The following is a description of a gene set: Human Gene Set: MIR95_5P Genes predicted to be targets of miRBase v22 microRNA hsa-miR-95-5p in miRDB v6.0 with MirTarget v4 prediction scores > 80 (high confidence targets). species: Homo sapiens from publication Chen Y, Wang X (PMID 31504780), and this is the list of marker genes: LPP, ERCC4, FOXD4L5, HARS1 (histidyl-tRNA synthetase 1), MTHFD2, TXNRD1 (thioredoxin reductase 1), ERAP1, NKIRAS2, CD2AP, FRG2, HEXB, MEP1A, RIC1, AMN1, ACP7, MTR, SDE2, DOK6, PLEKHG3, PDE4D, FEZF1, SLC7A10, ATG14, IL10RA, STXBP4, CIPC, TMX3, RORA, KIF20A, GPM6A, COL19A1, SMAD2, NOL7, HGF, PRTG, TRMT9B, KCNJ2, DCAF5, PSMC2, MAP3K10, SGTB, C5orf15, BRPF3, NADK2, TOR1A, NOTCH1, MYO10, SLC12A6, CTBP2, TRA2A, FBXO33, ELMOD1 (NCBI Gene Id 648653), CD164, EIF4A1, OGA, INO80D, CPEB3, TRIM14, AK9, ANOS1, CACHD1, COQ10B (NCBI Gene Id 80219), COLGALT1, FGFR3 (NCBI Gene Id 55546), CSRNP2, POGZ, PTGS2, PPP1R12A, RFX3, CPEB2, DMRTA1, FST, SGK1, NRG1, GK, CD69, PRKAA2, ZDBF2, LSM8, NET1, TET3, ASB8, C2CD4B, TMEM33, YPEL3, PTBP3, MAGI2 (NCBI Gene Id 9863), SLC2A4RG, TGFB2, PTPN11, YOD1, TMEM252, MINDY2, FAM168A, LCORL, CAMK1, GSK3B, CLIP4, ALCAM, TFDP1, GTF2A1, PHOX2A, COP1 (COP1 E3 ubiquitin ligase), TAFA1 (NCBI Gene Id 494552), YIPF6, RORB, IDI1, RAP2A, TMEM200B, SNAPC1, KCNA3, TBX3, WWP1, DMPK, FGF18, INPP5A (NCBI Gene Id 3632), LPGAT1, DTWD2, PDIK1L, GABRA1, KITLG, LRRC39, SLAIN1, ZNF512B, MIER3, DLEU7, RNF180, SNX27, SPEG (striated muscle enriched protein kinase), DNAJC15, CLDN1, ZBTB20, ATL2, GPR63, ABTB2, CIR1, OCRL, SPDYE5, DHX15, B3GLCT, FAT4, MXD3, PTGER3, KLHL8, JKAMP, CDK17, PMS1, GTPBP2, ATXN1, PCGF3, NR3C1, PRKCE, PIK3CA, ZBTB21, MAP3K13, MBD5, PPP1R2, SEMA7A, POMGNT2, EBF3, KCTD9, NBEA, TMEM182, GPR65, TBCA, PPP6C, MAFF, SLTM, CAMSAP1, ERBIN, COX7A2, ANKRD22, TIAM2, PTPN4 (NCBI Gene Id 5775), CCDC50, RASSF8, CD28, CAV2, FAM222B, AADACL4, MYSM1, RAB11A, NXPH2, IFT56, FSIP1, GOLGA2, BCL6B, PLCL2, FBXO45, SCAMP1, GDAP2, MMUT (NCBI Gene Id 4594), PYGO1, GPATCH2L, MACIR, C5orf24, SESTD1, MYO1E, SEC14L1, PPP4R3A, SLC7A14, UBA6 (NCBI Gene Id 55236), JRKL, GRIA2, TMEM236, CCT5, ADCYAP1, IFFO2, PHF21B, MMP16, SLC35D1, PLEKHG1, PRPF38B, MAFK, SPDYE3, DYRK2, RRP15, RAD51C, STT3B, NUBPL, RIMS4, ZSWIM4, CASKIN1, LRATD2, ASTN2, AKIRIN2, MBTPS2, RSRC2, MSX2, ATP11B, ZBTB22, TMLHE, EVI5, PGBD2, STX12, TXNDC11, EPC1, HTR2A, CBFB, DRD1, IL27, N4BP2, POMGNT1, FAM216B, SMIM13, KCMF1, SKIL, ANKRD6 (NCBI Gene Id 22881), ARPC5L, PARVA, TMEM97, INTS6L, CBLB, STARD3NL, G3BP1, TCF12, ZEB1, SEMA4G, CRPPA, FNDC3B, TP53BP2, SDR9C7, FSD1L, CEP20, BAHCC1, AMOT, PDP1, C6orf120, ST6GALNAC5, ZNF550, ZNF770 (NCBI Gene Id 54989), DPYS, SPTY2D1, C1orf74, RANBP6 (NCBI Gene Id 26953), UBE2W, PDZRN4, ACTL6A, SREK1IP1, SPATS2L, TMED5, STAMBPL1, CEP43, MPZL3, IKZF2, CFAP418, GRK3, TMEM135, COL9A1, OSBPL6, RBM17, RS1, TMX4, SLC25A38, GNAQ, SETBP1, SELENOT, SRRM4, ARL8A, MOCS2, MBTPS1, SLC13A2 (NCBI Gene Id 9058), APOOL, CXCR4, FERMT3, ZC3H12C, GFOD1, ZNF345, LRRC59, SLF1, USP7, WDR44, PSTPIP2, ZNF461, PIKFYVE, SMAD9, HYCC1 (NCBI Gene Id 84668), SCN8A, DIS3, DIXDC1, TRIM5, AMFR, SPRY1, PIGH, FBXL5, ANKRD12, KDM5C, LARP1, PARP8, SMG8, PRMT2, PPFIA3, WIPF3, CASP7, SEMA3F, SLC24A4, ACTR8, PPP1R1C, MRPL19, FNIP1, CCNJ, CLASP2, STAB1, ZFP14, GEMIN2, CTSC, GDNF, PLK3, HOXC5, RETSAT, ATP6V0B, ZC3H6 (zinc finger CCCH-type containing 6), POLR2K, ST3GAL1, ACTR1A (NCBI Gene Id 10121), CCNE1, ZNF772, SAV1 (NCBI Gene Id 60485), TAGAP, RSBN1, LMNTD2, SLC25A22, FOXN4, GORAB, MBLAC2, STC1, OAZ1 (NCBI Gene Id 4946), IMPG2, ZNF106, CNTN1, C14orf39, CRAMP1, AFF4, MORF4L2, EMC1, TMTC2, MYCBP2, TET1, MYT1L, ICAM1, LRP2BP, ZNF215, FRK, TEAD1, ARF1 (NCBI Gene Id 375), WNT4, MYCT1, ZDHHC21, THOC2, SPART, WDR7, ACTC1, CCDC86, MBIP, OCIAD1, RALGAPA1, MYLK3, CCDC181 (NCBI Gene Id 57821), TBL1XR1, PPIL4, CHSY3, YTHDF3, TBX5, SELENOI, KIAA1549L, ATP6V1A, ZNF264, ANAPC10, DERL1, IRAG2, DERL2, TMEM170B, EPHA5, MORC3, P4HTM (NCBI Gene Id 54681), FAM180A, ZNF609, CXCL1, FRA10AC1, REST, HOXB2, INO80E, PIM3, RAD51B, DTD2, PIAS2, GNL1, PPP2CB, KCNA4, HOXA9, PLEKHG5, RAB3A, SCG2, CCDC43, GPCPD1, ATP2A1, NOX1, NRXN3 (neurexin 3), CTNS, RNF139, UBE2B, CCSER2, ANKRD42, PCDH9, RO60, PPP1CB, FGG, C16orf87, INTU (NCBI Gene Id 27152), CPD (NCBI Gene Id 1362), PAPSS2, NPR3, FIGNL1, SLC24A3, PDXP, THSD7A, TWIST2, RNF38, SYNCRIP, PCDH18, VGLL3, CALCRL, BLOC1S6, PPFIA1 (PTPRF interacting protein alpha 1), YIPF5, CSNK1D, BYSL, QSER1, NUDT21, LEO1 (NCBI Gene Id 123169), DIPK1A, RPF1, PCDH15, RCOR3, SLC25A4, TFCP2L1, ATP2A2, OLFM3, RETREG1, P2RY1, PABPC4, CA8, CPNE3 (NCBI Gene Id 8895), CILP2, KMT2C, SPTBN1, GGACT, PREX1 (NCBI Gene Id 57580), SNAI1, SLC7A6, RYBP, CDC42BPB, IL19, FOXN2, IL2, HDAC4, RNF19B, PPP3CA, NEUROD1, ISM1, OTUD7B, TMEM117, VPS37A, MOB1B, FOXJ3, CACNB4 (calcium voltage-gated channel auxiliary subunit beta 4), ATP6V1C1, TTC28, MID2 (NCBI Gene Id 286440, midline 2), C9orf72, GATAD2A, CLOCK, CDH8, KLHL24, CARD16 (caspase recruitment domain family member 16), AGPAT5, SOCS5, RAB3B, SEMA6C, TRIT1, SEMA6A (NCBI Gene Id 57556), CSRNP3, ADAMTS5, NOTCH2, FEM1C, PAFAH1B2, ZNF24, SRF, IRF9, BCL11A, NUS1, ZNF829, IDS, CNTN5, LOX, COMMD8, ZNF41, ZNF678, RNF217, NAV3, ANKRD50, ADAMTS6, ZNF780B, NFAT5, SLC2A13, SAXO2, CXCL2, SLITRK6, PITPNM1, WDR35, SLC12A4, MBD2, BRSK1, BAMBI, HIC2, IFIT1, SERPINB13, PRPF39, LONRF3, TENT4B, SLC25A44, ADAMTS9, SUZ12, APBB3, HOOK1, BACH2, QKI, SPIN4, BRD1, LAMC2, TOX, LATS2, HIVEP1, ABHD13, BPTF, HOXD3, LRATD1, COX5A, PAX5, ARK2N, FAM135A, ARHGEF2, DGKH, ADAM17, PHIP, NKX2-2, SLITRK5, RRN3, JAG1, NCS1, JUNB, NCEH1, VEZF1, ILF2, AMMECR1L, RSPO3, SH3TC2, TWIST1, RNF19A, PDSS1, IRAK3, CHST11, CD300LF, HBS1L, TUT7, CEP162, SCN2B, SPRING1, GOLM2, CUL3, FAM3C, DMP1, MAPK6, GPR176, FRMD4B, PCDH17, CLINT1, PUM2, TFEC, EHD2, RAC2, SMIM17, RPE, HOOK3, PIN1, UNC5D, RELT, HNF4G, SREBF1, TICAM1, STX17, NMUR2, IGF2R, USP34, MSI2, PSD3, FGF14, SH3GLB1, FLG, RFX7, SRGN, HERC3, PLCH1, TRPC5OS (NCBI Gene Id 100506619), GPRIN3, HMGXB3, RIMOC1, ACADSB, DIPK2A, KLHL17, ZNF585A, IL31, PTPRO, NCK1, SLC25A53, CHIC1, SP3, LEMD3 (LEM domain containing 3), PTPRK, CLMN, BDNF (brain derived neurotrophic factor), KLHDC1, RNF121, DDX3X, SKIC8, PDCD6IP, PRR5L (NCBI Gene Id 79899), HECA, NEK5, CCDC69, JADE3, SLIT2